Given this list of marker genes RFX5, ECI2, KRT8, XRRA1, KCNB2, CHCHD5, BTBD1, THNSL2, VANGL1, SNAI3, OVOL3, FXR2, CCDC68, FARP1, MAP1LC3A, POGK, TLR3, DZANK1, BAALC, GRXCR1, SPATC1L, SNX1, SLC4A4, IFT43, CXCL9, CEL, SERPINE2, C6orf58, CCL4, VSIG10L, ATL2, FILIP1L, TSPAN2, GNAL, ACY3, LGR4, CDC42BPG, LNX2, PTPN23, USP9Y, PPP1R10, DNASE2B, ATXN7L3, PMP2, TRERF1, LRFN3, ZBTB17, KLHL26, RAPGEF5, NFYA, MIR31, FIGLA, VSIG4, ACBD7, CCDC81, SLAMF9, KIF27 (NCBI Gene Id 55582, kinesin family member 27), CCN6, MED12L, B4GALT5, AHCYL1, NXF1, BATF2, TFDP2, C1orf185, TBC1D2, BDKRB1, HOXB2, C1orf141, SPOCD1, CTNNAL1, NR4A1, GNRH1, SAA3P, ENO4, CCDC18, CP, TACR3, AKAP6, VWA8, MRPL47, CDK14, RANBP3L, DGLUCY, SLC22A9, MIR300, CDC42BPA, IDH1, HMGCS1, PIK3R6, DDN (NCBI Gene Id 23109), FAM219B, CUEDC1, C11orf91, EMILIN2, CSPG4BP, FABP12, CEMIP2, RAD51D, IL21R (NCBI Gene Id 50615), FBXO27, DDX28 (DEAD-box helicase 28), ZFP30, CD63, CYLC1, FAM81A, TRIM80P, JAM2, RDH16, SULF2, RTRAF, MAGEB17, NLRP2, KDM4D, AP3S1, LAMP5, PODNL1, CLNK, TERB1, IFITM5, OTX1, PSMA2 (NCBI Gene Id 5683), DCAF12L1, here is a description of the gene set: from publication Bürckstümmer T, Baumann C, Blüml S, Dixit E, Dürnberger G, Jahn H, Planyavsky M, Bilban M, Colinge J, Bennett KL, Superti-Furga G (PMID 19158679) Cytoplasmic DNA triggers the activation of the innate immune system. While downstream signaling components have been characterized, the DNA sensing components remain largely elusive. We performed a systematic proteomics screen for proteins that associate with DNA, traversed to a screen for IFN-β-induced transcripts. We identified DSIRE (DNA sensor for the IL-1β response, previously called AIM2) as a candidate cytoplasmic sensor. DSIRE showed a marked selectivity for double-stranded DNA. DSIRE can recruit the inflammasome adaptor ASC and gets redistributed to ASC speckles upon coexpression of ASC. RNAi-mediated reduction of DSIRE expression led to an impairment in IL-1β maturation. Reconstitution of unresponsive cells with DSIRE, ASC, caspase 1 and IL-1β showed that DSIRE is sufficient for inflammasome activation. Overall, our data strongly suggest that DSIRE is a cytoplasmic DNA sensor for the inflammasome. studied in species Homo sapiens Human Gene Set: GSE14413_UNSTIM_VS_IFNB_STIM_L929_CELLS_UP Genes up-regulated in L929 cells (fibroblast): control versus stimulated with IFN-b.